The following is a description of a gene set: from publication Chen Y, Wang X (PMID 31504780) Human Gene Set: MIR4714_3P studied in species Homo sapiens Genes predicted to be targets of miRBase v22 microRNA hsa-miR-4714-3p in miRDB v6.0 with MirTarget v4 prediction scores > 80 (high confidence targets)., and this is the list of marker genes: NPTX1, JADE1, TDRD10, KLF8, BAAT, SMARCB1, SLC35G1, MTSS1, UBE3C, GNAQ, TMEM65, NOVA1, PCDH7, CPSF7, BDP1, MPZL2, SLC9A7, TENM3, THBS2, CTCF, TPH2, PGRMC2, KPNA4, SMC5, CCNT1, SLC44A5, PRR23C, PLA2G4A, WDHD1, HGF, RYK, RERG, DENND4C, TRIP11, KCNQ3, NDUFC2, MYBL1, ELOVL6, TTC39C, SP4, TSC22D1, TTL, KLHL24, TRPA1, KCNJ3, SERPINB13, AMMECR1L, ZNF248, PAPOLA, SLC41A2, RAB5B, DCUN1D3, SETD7, PCDHB6, PHIP, TSPAN6